The following is a description of a gene set: Mouse Gene Set: REACTOME_SPHINGOLIPID_CATABOLISM Sphingolipid catabolism species: Mus musculus, and this is the list of marker genes: Sgpl1, Plpp1, Aldh3b1, Aldh3b2, Acer1, Sgpp1, Sgpp2, Plpp2, Acer3, Plpp3 (NCBI Gene Id 68448), Aldh3a2, Acer2